Given this list of marker genes POLR2C, POLR2D, GTF2F1, POLR2F, POLR2B, POLR2J, NCBP2, SUPT5H (NCBI Gene Id 6829), POLR2E, NELFCD (NCBI Gene Id 51497), MNAT1, POLR2H, NELFE, GTF2H1, CCNH, ERCC3, NCBP1, POLR2L, POLR2K, GTF2F2, CTDP1, POLR2A, NELFA, SUPT4H1, POLR2I, GTF2H5, NELFB, GTF2H4, GTF2H2, POLR2G, ERCC2, GTF2H3, CDK7, here is a description of the gene set: part of: RNA Polymerase II Transcription Elongation studied in species Homo sapiens Transcription elongation by RNA polymerase II (RNAPII) is controlled by a number of trans-acting transcription elongation factors as well as by cis-acting elements. Transcription elongation is a rate-limiting step for proper mRNA production in which the phosphorylation of Pol II CTD is a crucial biochemical event. The role of CTD phosphorylation in transcription by Pol II is greatly impaired by protein kinase inhibitors such as 5,6-dichloro-1- ribofuranosylbenzimidazole (DRB), which block CTD phosphorylation and induce arrest of elongating Pol II. DRB-sensitive activation Pol II CTD during elongation has enabled the isolation of two sets of factors -Negative Elongation Factors (NELF) and DRB sensitivity inducing factor (DSIF). P-Tefb is a DRB-sensitive, cyclin-dependent CTD kinase composed of Cdk9 that carries out Serine-2 phosphorylation of Pol II CTD during elongation.<BR>The mechanism by which DSIF, NELF and P-TEFb act together in Pol II-regulated elongation is yet to be fully understood. Various biochemical evidences point to a model in which DSIF and NELF negatively regulate elongation through interactions with polymerase containing a hypophosphorylated CTD. Subsequent phosphorylation of the Pol II CTD by P-Tefb might promote elongation by inhibiting interactions of DSIF and NELF with the elongation complex.<BR> Reactome Pathway: Formation of the Early Elongation Complex